The following is a description of a gene set: Human Gene Set: NKX62_Q2 studied in species Homo sapiens Genes having at least one occurrence of the motif NWADTAAWTANN in the regions spanning 4 kb centered on their transcription starting sites. This matches the NKX6-2 transcription factor binding site V$NKX62_Q2 (v7.4 TRANSFAC)., and this is the list of marker genes: BCL11A, SSH2, MYT1, CCNG1, NAALADL2, FOXN3, PDGFRA, TGFB3, ETS1, SIX3, SYNGR4, KCNN3, DMD, ATP2A2, PGR, LRP5, FGF13, COL11A2, HOXC11, GSX1, EMID1, RASSF9, ETV3 (ETS variant transcription factor 3), ERG, ACO2, IKZF3, LGALS12 (NCBI Gene Id 85329), RHOBTB1, KRT26, FAM169BP, TBX6 (T-box transcription factor 6), ITGA7, AP1S2, CHCHD7, RCAN1, RPLP0, MUC15, XPO1, RPL34, DIXDC1, FARP1, ADAMTS17, HESX1, CHD2 (chromodomain helicase DNA binding protein 2), DACH1, ANKRD39, LRFN5, TRMT112, DNAJB7, SLITRK1, PRIMA1 (proline rich membrane anchor 1), SHOX2, LRRTM4, WDPCP, OTUD7B, RBFOX1, IL5, PRKAG1, C1QTNF3, STX7, RFT1, CAVIN2 (NCBI Gene Id 8436), NKX2-2, LRRTM3, IRAK1, TWIST1, UNC13D, ZBTB18, ANGPT1, NFIX, SCML1, BEND4, CADM2, LTBP3, ITPR3, ARTN, HOXC4, CEND1, STAT3, CRYBG2, SLIT3, NHLH2, MSRB3, WNT3A, ZFPM2, PNMA1, NUFIP2, NEUROD2, ZNF524, FLRT1, IFIH1, BAD, IRS1, OFCC1, BACE2, FOXB1, KDM5C, MAFA, STMN2, PRDX5, TMEM94, RAB6A, HOXA4, YRDC, CCDC85B, FAM27E5, ABCB1, PLAG1, FLRT3, LMO3, RTN4RL1, PTF1A, SERTAD4, FILIP1, MAB21L1, ACTR10, AP1G1, GREM1, SLC37A4, TNR, NLGN2, BCL9L, CACNB3, SLN, BTBD3, TMEM178A, MITF, MED12L, KCP (kielin cysteine rich BMP regulator), OGG1, MRPL49, SLC44A3, UBE2E4P, C6orf136, PRKAA1, ATP2A3, PHF5A, MARVELD2, CALD1, FGF19, TLE3, FIZ1, SCRT2, PAK1IP1, BARHL1, ELMO1, CDC42EP3, CLDN4, ZIC1, OTX2, SOX15, LINC03122, TP63, NFIL3, SCUBE3, CYFIP2, SLC7A9, ATOH1, BMX, CYCS, MYO1B, HOXC6, CDKN2C, CACNA2D3, ADAM11, ANKH, DAB1, TGM3, FLOT1, DTNA, CAP1, C1orf122, MARCKS, TCEAL1, JPH3, PRDM1 (PR/SET domain 1), POLR2C, KRT32, PIK3R3, TMEM143, GNAI1 (G protein subunit alpha i1), ZIC4, CDIN1, PDZRN4, ZBTB20, EYA1, ASCL4, SMARCA2, KAT6B, DLG2, IRX6, NKX2-1, GARIN1B, TSPAN7, TNRC6A, IER3, TNFSF10, MSTN, IRX4, ELAVL4, NPAS2, PELI2, HOXA11, FIGN, SMTNL2, MYOG, FABP4, DLX1, TSC22D3, PHF21A, BAMBI, DIP2B, KCNS1, TSPAN8, PART1, ENSG00000291228, ETV4, ZNF436, TBX5, KDM6A, CADM1, TENM3-AS1, RIPK4, UNC5B, CGN, BNC2, EPB41L3, FEZF2, AQP6 (NCBI Gene Id 363), NPVF, RPL34-DT, PTH1R, NOL4, ZNF436-AS1, ARHGEF38, MEF2C, TTC29, SLCO5A1, SLC20A1, LUZP1, CYLD, HOXA10, STK38, SOX14, SIK2, GAL3ST4